The following is a description of a gene set: Murine Cytomegalovirus (MCMV) infection leads to early activation of various immune cells, including B and T lymphocytes, before the actual initiation of antigen-specific adaptive immunity. This activation is partly driven by innate cytokines, including type I interferon (IFN), which are induced early after infection. The objective of this study was to address the role of type I IFN in shaping early/innate B and T cell responses to a primary acute viral infection. In order to decipher the specific impact of IFN-I on cell subsets, we performed a genome-wide expression analysis on WT splenic B and CD8 T lymphocytes isolated from C57BL/6 mixed bone marrow chimera mice. This study complements series GSE39555, which focused on early responses of NK cells and of the two subsets of conventional dendritic cells. Human Gene Set: GSE45365_CD8A_DC_VS_CD11B_DC_IFNAR_KO_DN Genes down-regulated in dendritic cells with IFNAR1 knockout: CD8A versus ITGAM+. species: Homo sapiens, and this is the list of marker genes: OXR1, RDH10 (NCBI Gene Id 157506), BANF2, HAS2, KLLN, ZNF318, INO80D, MUC2, ARFGEF1, EIF4EBP2, RBM45, GPC3, SLC5A8, CYP26A1, TMEM74, LINC00930, PLEK2, PLIN2, COX6C, SLC35F6, ADI1, TATDN1, FAM117B, TNK1, RADX, HJURP, C8orf34-AS1 (C8orf34 antisense RNA 1), NDUFB3, CHN1, SERPINB6, ATIC, PRPF40A, ENPP7, XRCC5, NCL, FAM13A, ADAT2, RAMP1, GLA, ENPEP, DLAT, MTHFD1, EXOC2, H1-2, BCS1L, ATPAF2, HOXA10, BMP8A, VPS13B, TAB1, SEPTIN2, ARPC2, WFDC9, PCMTD1, DCAF13, STYX, NSMCE2, PLAG1, RARRES2, HSPA1A, GCNA, GFOD1 (NCBI Gene Id 96191), HHLA1, VEGFC, RRP7A, TUSC1, THOC5, FAM91A1, MIEF1, VPS37A, ZFAND1, FAM50B, DUXAP9, EFEMP1, PCM1, CHD7, CHMP4C, CYRIB, STMN4, HCG22, PRR3 (proline rich 3), NDUFAF6, TMED8, ELAVL3, PRUNE1, SAMD11, ADGRG6, TMEM177, ZFAT, SLC16A7, PPM1A, TAF2, EEF1D, PCARE, EIF3H, CAB39, RBPMS, MRPL50, HSPH1, CDK5RAP2, COL2A1, LAMA4, SSU72L6, AVEN, RNF144B, RIDA, FBXO25, TMEM237, GAR1, MRPL13, EXOSC4, TRMT11, DEFB121, TANC1, JPH1, PLEKHB2, NSMAF, LANCL2, PNMA8A, MSMB, POLR1E, PCDH20, FBXW7, PI3 (peptidase inhibitor 3), IFI16, ASCC3, RAD21, XYLB, PLPBP, GAPDHP62, GAS1, PTK2, GOPC, TNFSF13B, HECW1, TEX11, NDUFB9, UQCRB, SNORA71A, GCAT, NME8, NAA30, CTSO, KCTD9, TARS1, UCK2, HOXB6, SYBU, LRRTM4, DEPTOR, LILRB3, PYCR3, UAP1, AARS1, REC8, PHF23, CTHRC1 (NCBI Gene Id 115908), MAP4K5, PSMC5, HSPD1, GPR155, SARS1, RNF139, WNT8B, CCKBR, TRIOBP, UBXN2B, METTL21A, FABP5, GORASP2, TXK, ZNF142, MTCH1, PHF11, LINC01056, ZNF16, RNH1, EBAG9, FLG, TSN, AHSA1, SP3, RPL8, FBXL19, TBC1D31, UBE2J1, PHF20L1, PPP1R16A, ZFPM2, ENSA, EXTL3-AS1, WASHC5, LYRM4-AS1 (LYRM4 antisense RNA 1), VPS28, AGER, RBM23